The following is a description of a gene set: Human Gene Set: REACTOME_ROLE_OF_SECOND_MESSENGERS_IN_NETRIN_1_SIGNALING Role of second messengers in netrin-1 signaling studied in species Homo sapiens, and this is the list of marker genes: DCC, TRPC7, PLCG1, TRPC5, TRPC6, NTN1 (NCBI Gene Id 9423), TRPC1, TRPC4, TRPC3, PITPNA